Given this list of marker genes SLC19A2, GEMIN6, CTDP1, ANKRD46, RSL1D1, NFAM1, AKAP8, TREML4, SUV39H1, RCAN3, AIMP2, ERCC5, SLC20A1, ZNF518B, CPSF4, RALGPS2, IDH3A, DSCC1, NUDT16L1, PLEKHG3, ACP6, XPA, BPGM, NCAPD3, TRADD, WDR75, RREB1, CDC14B, CD1D, DHODH, ARPC3, AGPS, TMEM60, DMAC2L, PGLS, UTP15, RPF1, TFDP1, HSPD1, HNRNPR, RMND1, DNAAF2, TAF13, PAG1, TRAIP, THYN1, GK5, ARPC5L, RHEBL1, ZNF622, GMPR2, NLRC3, TUSC1 (NCBI Gene Id 389708), CARNMT1, ADIPOR1, POLD2, TSSC4, MRPL11, SPAG5, PPM1D, SGSH, CXCR4, HAUS6, SETDB1, C6orf62, GCLM, TMEM86A, MID1IP1, FAM219B, TBCC, HPGD, CIAO1, JAGN1, FBXO31, XPO1, NGRN, HAUS5, CKLF, TEDC2, GPR160, PGRMC1, ERI2, FCSK, EXO1, ABCD4, SEC11A, PRUNE2, DARS2, NEK9, OLA1, PPP1CC, CDC6, TATDN1, GAB3, SSNA1, GEMIN4, RECQL, PIF1, DCTPP1, ECSIT, MLH3, ADPRS, E2F2, ARHGEF10L, BTF3L4, MRPL18, C2orf69, ZNF808, SLC29A1, HASPIN, NAPG, C11orf58, CEP43, LRRC40 (NCBI Gene Id 55631), FAHD1, TUBA4A, TACC2 (NCBI Gene Id 10579), PSMA1, RAB3A, TARS2, LAMA3, RHOV, RNF7, GEMIN2, SH3PXD2A, NADK2 (NAD kinase 2, mitochondrial), FEM1B, TCEAL8, RNF166, CD163 (CD163 molecule), DELE1, ATMIN, ZFP3, RMDN1, GPCPD1 (glycerophosphocholine phosphodiesterase 1), FANCF, PITHD1, TM9SF3, C6orf118 (NCBI Gene Id 353266), SMYD4, MTRR, OSBPL11, RAC1, NEDD8, EIF1AD, SAMD8, AGPAT5, TUFM (NCBI Gene Id 7284), ENY2, TRUB2, PIK3CG, INTS7, PSRC1, TMEM154, MDK, STAMBPL1, UQCR10, ABHD5, EXOSC8 (exosome component 8), SS18, RARS2 (arginyl-tRNA synthetase 2, mitochondrial), ERH, LRRC20, TXNL4A, MNT, NUDCD2 (NCBI Gene Id 134492), ATG4C, KIAA0513, RGS19, CHCHD4, RPP30, DEK, PITPNB, EFNB1, MAP3K9 (NCBI Gene Id 4293), TIMM22, CCDC47, UNG, BCL2L12, PPCDC, ALG2, SLC36A4, TBC1D10A, ZNF511, HELLS (helicase, lymphoid specific), ZCCHC24, MMS22L, ORC6, METTL8, CLXN, PLEKHH3, KCNN2, LAMTOR1, PRMT7, DYNC2I2, AGO4, PYCR2, C8orf58, ATOSA, THSD1, here is a description of the gene set: Human Gene Set: GSE14769_UNSTIM_VS_240MIN_LPS_BMDM_UP Genes up-regulated in comparison of unstimulated macrophage cells versus macrophage cells stimulated with LPS (TLR4 agonist) for 240 min. The innate immune system is a two-edged sword; it is absolutely required for host defense against infection, but if left uncontrolled can trigger a plethora of inflammatory diseases. Here we used systems biology approaches to predict and validate a gene regulatory network involving a dynamic interplay between the transcription factors NF-κB, C/EBPδ, and ATF3 that controls inflammatory responses. We mathematically modeled transcriptional regulation of Il6 and Cebpd genes and experimentally validated the prediction that the combination of an initiator (NF-κB), an amplifier (C/EBPδ) and an attenuator (ATF3) forms a regulatory circuit that discriminates between transient and persistent Toll-like receptor 4-induced signals. Our results suggest a mechanism that enables the innate immune system to detect the duration of infection and to respond appropriately. from publication Litvak V, Ramsey SA, Rust AG, Zak DE, Kennedy KA, Lampano AE, Nykter M, Shmulevich I, Aderem A (PMID 19270711) studied in species Homo sapiens